The following is a description of a gene set: Hyperconvex fingernails studied in species Homo sapiens When viewed on end (with the finger tip pointing toward the examiner's eye) the curve of the fingernail forms a tighter curve of convexity. Human Gene Set: HP_HYPERCONVEX_FINGERNAILS, and this is the list of marker genes: LETM1 (leucine zipper and EF-hand containing transmembrane protein 1), PTDSS1, MBTPS2 (membrane bound transcription factor peptidase, site 2), CPLX1, CTBP1, FGFRL1, RPS6KA3 (NCBI Gene Id 6197), PLEC, NSD2